Given this list of marker genes GTF2IRD1, COL2A1, TRIM28 (NCBI Gene Id 96054), TP63, TMEM67, NSD2, TCTN3, EPS15L1, BRCA1, FAM111A, DIS3L2, FANCC, MDH2, WT1, SALL4, LMX1B, GTF2I, XYLT2, PAX6, SLC25A11, IGF1R, CPAMD8, FBN1, FBXW4, HMX1 (H6 family homeobox 1), NDP, FGFR1, RAD51, FKBP6, H19, RET, GPC3 (glypican 3), MAX, BUD23, ERCC6, HS2ST1, LETM1, SDHAF2, BRIP1, NF1, BRCA2, VSX1, XRCC2, SDHC, WNT10B, CC2D2A, FH, BDNF, FANCA, TXNDC15, FANCM, TMEM237, GTF2IRD2, ERCC4, FANCB, UBE2T, MAFB, PITX2, FANCI, POU6F2, LDHD, TRIP13, TBL2, MT-CYB, TCTN1, ADAMTSL1 (ADAMTS like 1), DLST, RRAGC (Ras related GTP binding C), BAZ1B, FANCD2 (FA complementation group D2), FGFRL1, PALB2, SDHA, BTRC, TMEM216 (NCBI Gene Id 51259), KIF1B, SDHD, RPGRIP1L, FBXW11 (F-box and WD repeat domain containing 11), LRP2, TMEM231, TCTN2, VHL, SOX10, LAMB2, TONSL, PRR12, MITF, REST, HHAT, LIMK1, TMEM270, LTBP2, FANCG, WDR73, NCF1, B9D2, PAX3, CHN1, PORCN, SLX4, SEM1, DNAJC30 (NCBI Gene Id 84277), FANCF, TMEM127, PIK3R1 (NCBI Gene Id 5295), ITPR1, TRIM44, COL4A1, MAD2L2, EIF4H, STX1A, ELN, B9D1, STIM1, SDHB, DLX6, ADAMTS10, CPLX1, VPS37D, METTL27, RFWD3, TMEM107, CLIP2, ELP4, FOXE3, FANCE, RAD51C (RAD51 paralog C), MKS1, CEP290 (centrosomal protein 290), FANCL (NCBI Gene Id 55120), MIR184, CTBP1, FGF3, RFC2 (replication factor C subunit 2), ADAMTS17, RPGRIP1, FOXC1, CSPP1, DLX5, here is a description of the gene set: studied in species Homo sapiens Absence or underdevelopment of the anterior segment of the eye. Aplasia/Hypoplasia affecting the anterior segment of the eye Human Gene Set: HP_APLASIA_HYPOPLASIA_AFFECTING_THE_ANTERIOR_SEGMENT_OF_THE_EYE